The following is a description of a gene set: Human Gene Set: MIR6871_3P species: Homo sapiens from publication Chen Y, Wang X (PMID 31504780) Genes predicted to be targets of miRBase v22 microRNA hsa-miR-6871-3p in miRDB v6.0 with MirTarget v4 prediction scores > 80 (high confidence targets)., and this is the list of marker genes: BVES, ABHD5, ZMIZ1, FSTL1, KMT5C, SLK, SETDB2, XKR4, TET3, ZNF639, KIF26A, REPS2, PPP1R3B, PDIK1L (NCBI Gene Id 149420), HBP1, WNT8B, BLTP3A, MED26, SERPINH1, MBD5, ZNF282, DYNLT1, IFI30, SERF1B, DNMT3B, ATAD2B, OPN3 (NCBI Gene Id 23596), CALCR, SIDT2, CBX6, TRIM9, TRAF3, SGCZ, GLE1, DTWD2, CEP97, IREB2, ARL14EP, LYPLA1, UBE2Q1, ANKRD13A, PMP22, ZHX3, SP1, IQCJ-SCHIP1, SPARC, CARMIL1, B4GALT2, BTG2, USP43, HMBOX1, KDM7A, AKT3, BDKRB2, ADAMTS9, LYSMD1, TFEB, COL3A1, SESTD1, RAB30, CALM3, MBTD1, ZNF396, COL15A1, PPP2R5D, NEXMIF, FABP3, KDM5B, PIK3CB, P2RX5, AFAP1L1, PRKG1, IL1RAP, RNF19A, COL1A1, EIF3J, CCNY, DGKH, TRIB2, RALGPS1, KNOP1, NPAS3, COL4A1, CDK6, ZFP36L1, PPIC, FYN, PPP1R14C (NCBI Gene Id 81706), FBN1, EPC1, ADAMTS7, SRSF10, COL19A1, ATAD1, IGF1, PXYLP1, IPMK, DENND2B, COL5A1, ITGA4, NFATC3, COL5A2 (collagen type V alpha 2 chain), FRMD5, IRGQ, ROBO1, COL5A3, JAZF1, NSD1, ADAMTS17, COL2A1, WWTR1 (NCBI Gene Id 25937), NKIRAS2, RLF, TEAD2, CLDN1 (NCBI Gene Id 9076), GAS7, DOCK3, CAV2, PXDN, CX3CL1, TLL1, C1orf52, DOCK11, P2RY1 (NCBI Gene Id 90963)